Given this list of marker genes UBA1, IL2RA, GBA1, HBG2, ASAH1, CCR1, APOE, RAB27A, MEFV, SFTPB, UBAC2, IL12A (interleukin 12A), IFNGR1, SLC34A2, FAS, NKX2-1, MALT1, BCL10, HLA-B, BTNL2 (NCBI Gene Id 56244), FOXP1, KLF1, CCN2, PRIM1, DOCK2, HBB, PTPN22, PDGFRA, C4A, ERAP1, IL10, SMPD1, TSC1, PRTN3, CAV1, TSC2, HBG1, KLRC4, HLA-DPA1, LPIN2, IL23R, CASP10, CTLA4, BIRC3 (NCBI Gene Id 330), BCL11A, CCR6, HLA-DPB1, MYD88, STAT4, IL12A-AS1, BACH2, ABCA3, IRF5, SLC41A1, TLR4, HLA-DRB1, FASLG, here is a description of the gene set: Pulmonary infiltrates Human Gene Set: HP_PULMONARY_INFILTRATES studied in species Homo sapiens